The following is a description of a gene set: species: Homo sapiens Human Gene Set: GSE27786_NKCELL_VS_ERYTHROBLAST_UP from publication Konuma T, Nakamura S, Miyagi S, Negishi M, Chiba T, Oguro H, Yuan J, Mochizuki-Kashio M, Ichikawa H, Miyoshi H, Vidal M, Iwama A (PMID 21540074) Genes up-regulated in comparison of NK cells versus erythroblasts. Each fraction of mouse hematopoietic cells was purified by cell sorting from bone marrow of 8-week-old C57BL/6 mice, and its gene expression was analyzed., and this is the list of marker genes: LRIF1, PPCDC, SRF, DCTN1, ZDHHC4, MRPS16, ZMYM4, KIAA0319L, STN1, DUSP7, PPP4R3B, VSIR, NOB1, TLR6, ACO1, ICMT, GLB1, TBC1D32, NHLRC3, GPR183, IKBKE, PDE4B, DNAJC17, PKD1, CD86, ZDHHC9, TAF3, FUS, HMGN3, TASL, NKAPD1, PTTG1IP, STXBP3, C2orf76, UNC93B1, CPQ, ZNF652, TMEM42, TRIM14, ZPR1, TMEM70, COPRS, RBFA, NAB2, TRMT1L (tRNA methyltransferase 1 like), NRBP1, PPHLN1, MRPS34, MFSD14A, PPA1, FAR1, MYO9B, CMKLR1, PKIB, CRYBG1, EED, ZNF569, RLIM, ADGRG5, NDUFS6, SGTA, SLC37A4, LIMS4, RHOT1, AAMDC, FMNL3 (formin like 3), ZFP90, CFP (NCBI Gene Id 5200), HES6, EIF4E3, STYK1, SURF1, WDFY4, AAK1, CPEB2, C14orf93, SEC63, AP5Z1, PECAM1, GSTM4, EXT2, NINJ1, MGA, TTC39B, RBM17, ZNF260, LMF1, DUS1L, MFGE8, UBR1, MTG1, ABHD11, CNOT2, JAGN1, SEPHS2, ZMIZ2, LSM14B, SIPA1L3, PTGR3 (prostaglandin reductase 3), SEC24D, DUSP12, RPL22L1, COG3, NDUFS3, TOGARAM1, HMOX1, MINDY3, GOLGA4, ASB13, OPA1, UBE2L3, COX10, ZNF32, LAMTOR1, COX17, PLXND1, TMEM120A, PTPN12, MRPL42, CCAR1, MARVELD1, CALU, UBQLN4, RPL24, TRIM45, ARF6, ZBTB33, TNKS2, G6PD, FBXO6, ARID1A, AXL, EXOC1, RPN2, ZC3H7A, WDR82, PPM1J (NCBI Gene Id 333926), YTHDF2, TTC5, PI4KA, SBNO1, TBC1D13, ZC2HC1A, LRP10, CAMLG, FKRP, FOXRED2, IRF2, COASY, ATG16L2, DDX50, ZMPSTE24, TRDMT1, MFSD8, SPAG7, NDUFA6, DHX57, ZC3H7B, ASL, PPP3CC, RRP36, FPGT (NCBI Gene Id 8790), PSMA7, FLOT2, SETX, PLSCR1, NXPE3, EIF2A, TMEM68, AZIN2, STX3, SANBR, GAK, TCF12, MAGI2, DHX15, TSPYL4, ACACA, CCDC9, KIT, NSMF, ACP3, BHLHE40, CYP51A1, HTRA2, ANKIB1, RHOH, NDUFS4, PRAM1, MBNL1, ATE1, PHF23, ZDHHC13, NCBP2AS2, BET1, CCDC115, B3GNT5, CDCA7L, MOCS2, CRNKL1